Given this list of marker genes UGDH, LTBP2, HTR3B, SLC38A6, HOXC4, DSG1, SLC8A1, CNTNAP5, LIFR, NNT, ULK1, PCK1, PLA2G6, GRPR, SLC43A3, RAB9A, HMGB2, MET, METAP1D, HOXA1, ARFGAP2, KRT34, RPS6KA3, SLC47A1, SOX5, SPON1, TDRD5, PDP1, GAD1, COLEC10, BMI1, VEGFA, GABRB1, MEPCE, ETS1, LOX, LRTOMT, SOX14, CSF2, POU3F4, DNAJB9 (NCBI Gene Id 4189), LAMC2, GRID2, VPS26A, SEMA3A, CRYGS, H4C3, DPH1, GRIPAP1, OTUD7B, ABCB5, EWSR1, TMEM196, PIP4K2B, RUNX1T1 (NCBI Gene Id 862), ARID4A, ROR1 (receptor tyrosine kinase like orphan receptor 1), MAPKAPK2, EFHC2, PYM1, MFGE8, THNSL2 (threonine synthase like 2), GDPD4, ZPBP2, GNAI1, CIZ1, HGF, SPTB, PCSK1, TFEC, ST3GAL4, ARPP21, MCTS1, FSTL3, AKIRIN2, TNIP3, SMPX, ELK4, PON1 (paraoxonase 1), CUZD1, PIK3R3, NPTX2, SKA2, SOX4, TRMT9B, HOXC6, GPBP1, LINC01565, DMD, SLIRP, NLGN1, BUB3, CCDC18, GPR88, STAC2, CPB1, LHX9, BCL9, PPP1R12A, LYPD3, GPX1, THAP5, SNX6, IL25, DCAF11, KRTAP6-2, LIN54, NFRKB, MAP3K13, CDH20, CDIN1, CCDC6, TMEM59L, GIMAP5, TECPR1, USP32, NR1H4, COL4A4, ERG, IL21, MPZL3, HAL (NCBI Gene Id 3034), RYBP, MINDY3, KCNIP2, LINC00955, ADAMTSL2, SESN2, CRHBP, ARHGAP6, HSD3B7, GPR158, NCDN, APOO, SKP1, PRPF3, NDST4, HNMT, TMEM126B (NCBI Gene Id 95018), LMX1A, CHN2 (chimerin 2), RAB11FIP5, TMEM88, STAM, POU4F3, PTPRO, MAP2, SLCO1B1, PAXBP1, HOMER2, RTN3, PTK7, SUCNR1, AKAP1, IL18BP, OMG, NT5DC2, EFEMP1, KRT14, PTPRK, CRLF1, CBX8 (chromobox 8), DNAJB1, DCLK1 (doublecortin like kinase 1), TAPBP, KRT23, GSG1, NLRP3, CABP7, ELK3, MAB21L1, CA8, ELMO3, NR3C2, CSRNP3, CES5A, IRX4, TRA2A, DPYD, ALK, DOCK7, UNC80, PPOX, GPD1, SLC44A1, COL4A5, VLDLR, SFN, DDX52, AQP3 (NCBI Gene Id 360), MTTP, RIPK4, IL5, ENSG00000291228, L1CAM, IL17RC, SYT16, TRAK2, GAP43, SRSF1, DLGAP4 (DLG associated protein 4), PDLIM5, NR2E1 (nuclear receptor subfamily 2 group E member 1), STRADB, FOXP2, DPF3 (double PHD fingers 3), NOTCH1, RBMS3, SREK1, KRTAP13-2, TAFA1, PRDM1, NSG2, MCF2, C5, SSMEM1, CORO1C, MGAT2, CERS6, RFX4, PPM1L, ABL2, DENND2D, KLHL34, RASGEF1B, ASCL1, S100A10, SALL1, CPNE4, RIMS1, WASF2, TIMP1, CNIH3, LINC03122, BHLHE40, KRT28, LINC01559, MTMR4, MSN, PDE1A, SCN2A (sodium voltage-gated channel alpha subunit 2), PCF11 (NCBI Gene Id 51585), VCAN, SCUBE3, FES, CMTM8, NCALD (NCBI Gene Id 93992), CD226, TSC22D1, NRP2, HS3ST4, GRWD1, MEA1, MASP1, AP2B1, COL8A1, RUNX1, GREM1, USPL1, LHX5, RTKN2, IGF1, HOXD3, ALKBH1, RELA, ERRFI1, C4BPA, ABLIM1, PIAS1, C8orf82 (NCBI Gene Id 414919), NDP, B3GLCT, KMT2E, DNAI1, COL4A3, RBMS2, DDX17, CCER1, SAT1, DNAJC22, TINAG, AAR2, RABEP1, KLHL13, PHF6 (PHD finger protein 6), BCKDHA, PAX6, CRTAC1, SPOPL, GPR150, BMPR2, PMP22, SDC4, SYT10, ZNF423, KCTD15, DENND2B, TGIF1, KLK9, CHL1, UBE3A, NUDCD2, ANKMY2, COMMD10, HMGN2, SFRP4, ATP6V1C2, FHL5, ZNF593, FABP6, KRTAP11-1, EYA1, KITLG, FMNL1, PPM1J, YRDC, CITED2, QRFP, FOSL2, RASSF8, SEMA5B, SEL1L, KRTAP6-1 (NCBI Gene Id 337966), MKS1, ABHD17B, STMN2, DNAH5, ZMAT3, CDK2AP1 (cyclin dependent kinase 2 associated protein 1), CAMKK1, GAL3ST3, XPC, NEDD4L, PJA1, CPNE1, ERBIN, ATP6V1B2, RAB1A, SLC7A11, LRMDA, ENGASE, RNF220, UCHL5, CREB5, SLAIN1, HMGA2, TSPAN2, ROGDI, TXNRD1, TRPM8 (NCBI Gene Id 79054), HOXD4, WNT11, TMEM59, ARPC5L, SAG, ZBTB2, ALDH1A3, MED13 (mediator complex subunit 13), ZMIZ1, APOOL, LBX2-AS1, SLITRK2, LMO3, PAX9, RGL1, CDX2, C3AR1, PAX3, FLT1 (fms related receptor tyrosine kinase 1), FGFR1, HBA2, SLC35B1, SLITRK6, GRIN2A (glutamate ionotropic receptor NMDA type subunit 2A), RPL27A, PRIMA1, ARAP2, PLS3, RYR2, ETS2, WDR81, RTN1, GPRIN3, OTUD4, KDM2A, MFSD2A, MAGI1, PLEKHA5, ESRRG, ASXL2, DPY19L3, HMMR, MED15, FBN2 (NCBI Gene Id 877), PDZD2, MIB1 (NCBI Gene Id 57534), AMY2A, ITIH2, FBXW7, BNC2, ATXN7L1, ATP10D, BNIP1, EIF1, IBSP, TMEM127, ELAVL2, UBA1, NPY2R, OTP (NCBI Gene Id 23440, orthopedia homeobox), HSPH1, TMEFF2, BZW2, PCDHB3, PMCH, TMOD3, ROBO3, DUSP1, MMP3, SIX1, SLITRK4, TTC12, TRERF1, KCNQ1DN, GOLPH3L, RAPGEF6, SIGLEC1, ELL, PART1, TAF6, CAMK2D, TBC1D21, TBR1 (T-box brain transcription factor 1), TAGLN2, POLR2K, SSTR5, TMSB4XP1, UQCRC2, BLOC1S1, ADAM11, FSIP2, AZIN1, MSTN, BEND4, SOD2, ZIC5, PKIA, FGA, WDR73, TCF7, ITPRIPL1, CREM, ZRSR2, SFR1, CUBN, FAM13B, EFNA5 (NCBI Gene Id 1946), IGFBP6, POU2F1, PHF8, KLRA1P (killer cell lectin like receptor A1, pseudogene), PRDM8, HOMER3, IL1RAPL2, AGAP3, RASA2, GPR119, TTR, PAK6, TECTA, SMARCA2, SLC9A5, BDKRB1 (bradykinin receptor B1), LTBP1, ASPA, PAK1, GFRA1, ZCWPW1, SSTR5-AS1, POLDIP3, XRN2, DBN1, SP8, NSD3, KNCN, PFN2, SKIL, MTFP1, FHDC1 (NCBI Gene Id 85462), LINC00052 (long intergenic non-protein coding RNA 52), IL13, GTPBP1, HMCES, TMEM255A, SELENOO, ABL1, RLIM, CNPPD1, ZBTB18, RRAGA, IP6K2, DUSP6, E2F3, KRT76 (keratin 76), LINGO2, MYO10, OTOF, ATP5MGL, SERPINA10, ZNF485, DSG4, LMO4, ACVR1, CPEB4, GPR34, FGF5, MARCHF5, DLX1, MITF, GIP, AP5B1, TMPRSS11D, MIR22HG, MICALL1, EDN1, HGFAC, KLHDC10, GPRC5D, JMJD1C, ACP6, NEFM, SULF2, DRD3, PTCH1, TBC1D5, PLCB2, EVI2B, BMP4, CLDN17, UBE2R2, RIN1, MTMR10, MAFF, KLHL24, SLC16A13, BACE2, RHBDD3, IL1RAPL1 (NCBI Gene Id 4399), GRIN2B, TAB3, LRRN2, LMO2, PCDH7, NIPBL, EBF2, JUP, KIRREL3, MFN2, SYTL2, HOXB3, REEP3, ATXN1, KIF5A, HOXC11, ACY3 (aminoacylase 3), SMARCA1, RETREG2, PRKCH, TREX1, PCDH11Y, BAMBI (NCBI Gene Id 25805), SERPINB2, DIS3L, KMT5C, SERPINI2, BAIAP2, TEF, FBXO11, NECAP1, BARHL2, SMAD1, MAP3K5, NEIL3 (nei like DNA glycosylase 3), CUX1, AQP9, CBFA2T2, CTNNBIP1, PRR11, CARTPT, SEZ6, LRRN1, DNAJC1, SLC5A3, CIAO1, HEXIM2, EMP1, FSCB, SLC37A4, CYLD, HOXB6, CLTC, PITX2, PAIP2, PITPNC1, MTX2, LRRFIP2, TSC1, NOL3, CLC, SRSF8, CNPY4, PTGS2, SLC41A1, ASTN1, TMIE, PURA, ANKRD44, RASSF1, UCHL3, CCL22, USP14, JAZF1, SLITRK1, CCN1, CAPG, MYF6, ADAMTS4, CARMIL3, FAM98B, CIPC, TCEANC2, FBXO30, SNTB2, ZEB2, C1orf122, PLAAT1, UBXN10, GPM6A, SLC10A2, RRBP1, CDK6, RNF141, MPZL1, MSS51, DGKA, CHRNA10, ITGA11, YIPF7, LINC00649, DGKI, ARPC5, AQP5, PROX1, GATA6, PANK3, IL18RAP, NMT2, ECI1, IFNK, TINAGL1, IGF1R, RPH3A, KCNIP4, MYLK, SYNPO, GPR107, ADAM33, PRL, SERPINB13 (NCBI Gene Id 54735), TBX19, KLHDC3, HTR2C, ACKR3, VIP, SH3BGRL2, NEUROG1, BRMS1L, TMSB4XP4, TRAPPC14, C11orf87, NEO1, BARHL1, SHISA6, SHANK2, VCPKMT, TREX2, ITPRIP, LARP7, POLG, SSTR1, CLCN4, CCN3, SDF2L1, JAKMIP2, ADAMTSL1, SPAG9, PAFAH1B1, CD68 (NCBI Gene Id 968), UXS1, GLRA2, MAP2K3, PDIA4, NSMCE3, ADCY8, ABI3BP, TMSB4XP8, SPINK7, NDUFS2, PGAP2, HNRNPR, ARF6, ZRANB1, RP1L1, HOXA9, TAS2R41, ADAMTS6, STIP1, PIM1, MYBPH, FGF10, ZNF689, PRDX4, RBM39, CD40LG, USP49, VAX1, CTNND2, KDM5C, ANKRD28, FAM219A, RBFOX1, TAC1, CPVL, FBXL19-AS1, CASQ2, H4C5, WNK1, ATRNL1, CASK, DCX, GAST, MARK2, PTPRR, ACTE1P, THOC6, LINC01164, WBP4, ZFHX4 (zinc finger homeobox 4), BEND5, CDK14, LARGE1, HIP1R, NEDD4, SOBP, TIAL1, PDE4D, NOG, CADM1, NUMA1, DNM1, SLC17A6, LIMK1, PLAT, GRB7, PDZD7, TYRO3 (TYRO3 protein tyrosine kinase), C7orf33, CALCOCO1 (calcium binding and coiled-coil domain 1), OPN5, TRIM33, GLRA1, NHLH1, TENM3-AS1 (TENM3 antisense RNA 1), FBXO44, WIPI2, EXOG, NR5A2, VPS50, WNT4, VSX1 (visual system homeobox 1), PTPRM (protein tyrosine phosphatase receptor type M), CXADR, RUNX3, CEBPA-DT, NFIX, SARNP, SCP2D1, MAPK8, TCOF1, ADGRL2, TTLL6, RPA3, AP1AR, SERPINB7, FAM178B (NCBI Gene Id 51252), CLDN8, KIZ, SLC39A13 (solute carrier family 39 member 13), KIF1B, PTPRG, CNTF, HOXA5, ATXN7L2, MYH10, IL3 (NCBI Gene Id 3562), HMGA1, TPI1, KIAA1549L, ZNF474, UBE4B (NCBI Gene Id 10277), RAB8B, CLDN2, TMCC1, MYO1B, C9orf85, SPIN2A, SULF1, FNDC9, HOXA2, KLF5, MAP2K1, DSG3, USP3 (ubiquitin specific peptidase 3), ZNF516-DT, MRPL58, CRYBG2, SLC25A13, ARL4C, SRPK2, TMCO1, CYP46A1, CPA5, ZNF532, FGF7, ACOXL-AS1, CEBPB, PRRX1, FCER1G, ZNF654 (NCBI Gene Id 84158), CXorf58, APRG1, ZFP91, WDR44, TJP2, SLC9A9, DLG2 (NCBI Gene Id 283225), ISL1, MESP1, SERTAD4, CDKN2C, STAG2, PRP4K, BCAR3, DLC1, BAIAP2L1, IKZF2, PRR7, UFM1, ADCYAP1, ACSL4, CDH9, FAM216B, CELA1, ADGRG6, PCDH9, CD44, AQP2, MRPS6, TMEM185A, PAK3, KCNA3, TNFSF4, ARHGAP24, TRPS1, PRICKLE1, HPSE2, THAP9, PRELID3B, MAL2, GOLGA4 (golgin A4), CEBPE, TMEM131L, NRAP, ILDR2, SOX10, EREG, SPRR2A, CYFIP2, WASF1, PPP2R2B (NCBI Gene Id 56686), IL13RA1, USP2, G3BP1, ZEB1, SMAP2, STMN4, TEX15, E2F1, CDC40, ESRRB, RBM33, GMCL2, ZIC2, MAPK14, CFAP54, FGF12 (fibroblast growth factor 12), EN1, GC, CNGB3, SLC30A3, SH3TC2, PCDH11X, TSHZ3 (teashirt zinc finger homeobox 3), BIN3, PRPF38B, PRR34, SPO11, NAALADL2, MYO3B, HIVEP3, GATB, NIPA2, NUMBL, SMIM29, VGLL4, CEBPA, MEIS2, SPAG16, HCFC1R1, HBP1, GCNT2 (glucosaminyl (N-acetyl) transferase 2 (I blood group)), TXN, LMAN1, SLC8A3, TCF7L1, RORB, GPR174, LGI2, MYH11, CPNE5, COL4A6, SLC39A2, ZMAT5, FLRT3, RCAN1, CEP57, MAPK9, SPAG1, ZFPM2, MSMB, PIK3CG, TMSB4XP6, BAIAP2L2, EPC2, CRIM1, CPEB3, S100A16, NABP2, FOXP1, MICALL2, B3GALT2, SCN3B, GAREM1 (NCBI Gene Id 64762), NFAT5, CASZ1, DLX4, FERMT1, here is a description of the gene set: Genes having at least one occurrence of the highly conserved motif M64 TTANTCA in the regions spanning 4 kb centered on their transcription starting sites. The motif does not match any known transcription factor binding site. studied in species Homo sapiens Comprehensive identification of all functional elements encoded in the human genome is a fundamental need in biomedical research. Here, we present a comparative analysis of the human, mouse, rat and dog genomes to create a systematic catalogue of common regulatory motifs in promoters and 3' untranslated regions (3' UTRs). The promoter analysis yields 174 candidate motifs, including most previously known transcription-factor binding sites and 105 new motifs. The 3'-UTR analysis yields 106 motifs likely to be involved in post-transcriptional regulation. Nearly one-half are associated with microRNAs (miRNAs), leading to the discovery of many new miRNA genes and their likely target genes. Our results suggest that previous estimates of the number of human miRNA genes were low, and that miRNAs regulate at least 20% of human genes. The overall results provide a systematic view of gene regulation in the human, which will be refined as additional mammalian genomes become available. from publication Xie X, Lu J, Kulbokas EJ, Golub TR, Mootha V, Lindblad-Toh K, Lander ES, Kellis M (PMID 15735639) Human Gene Set: TTANTCA_UNKNOWN